Given this list of marker genes NME1, ITPA, CTPS1, ATP5F1E, ADSL, HPRT1, RRM1, UMPS (uridine monophosphate synthetase), PAICS, ADK, GMPS, NME2 (NCBI Gene Id 4831), CMPK1, TYMS, ATP5F1B, ATP5MF, ATP5ME, GART (NCBI Gene Id 2618), DTYMK, NME4, RRM2 (ribonucleotide reductase regulatory subunit M2), APRT, PRPS2, ADA, AK2, MTHFD1, IMPDH2, here is a description of the gene set: studied in species Homo sapiens Human Gene Set: MODULE_219 Genes in the cancer module 219.